The following is a description of a gene set: studied in species Mus musculus Mouse Gene Set: GOBP_RENAL_WATER_ABSORPTION A renal system process in which water is taken up from the collecting ducts and proximal and distal loops of the nephron. In non-mammalian species, absorption may occur in related structures., and this is the list of marker genes: Ctns, Has2, Aqp4, Aqp1 (aquaporin 1), Sctr, Mllt6, Hyal2, Aqp3, Aqp7